The following is a description of a gene set: GLI1 is the most divergent of the 3 mammalian GLI transcription factors and lacks a transcriptional repressor domain. Although GLI1 is dispensible for development, the gene is an early transcriptional target of Hh signaling and the protein contributes a minor activation function in mammals.<br>In the absence of Hh signaling, GLI1 is completely degraded by the proteasome, in contrast to the partial processing that occurs with GLI3. This differential response reflects the absence in GLI1 of two of the three elements identified in GLI3 that promote partial proteolysis; these are the zinc finger region, present in all GLI proteins, and an adjacent linker sequence and the degron, neither of which are found in the GLI1 protein. Reactome Pathway: Degradation of GLI1 by the proteasome species: Homo sapiens part of: Hedgehog 'off' state, and this is the list of marker genes: PSMD13, PRKACB, PSMA4, PSMC6, RBX1, PSMA2, PSMA5, SUFU, NUMB, CUL1, PSMD1, PRKACA, PSMC2, PSMD14, UBB, PSMA6, PSMB6, PSMD8, SEM1, PSMB2, PSMD3, PSMD2, GLI1, PSMD12, PSMD11, PSMD7, PSMA3, PSMB5, PSMC1, BTRC, PSMA7, ITCH, UBA52, PSMC4, PSMB4, PSMC3, PSMB3, PSMB1, PRKACG, RPS27A, PSMC5, ADRM1, PSMA1, SKP1, PSMD6, UBC, PSMB7